The following is a description of a gene set: Human Gene Set: SMID_BREAST_CANCER_RELAPSE_IN_BONE_UP from publication Smid M, Wang Y, Zhang Y, Sieuwerts AM, Yu J, Klijn JG, Foekens JA, Martens JW (PMID 18451135) studied in species Homo sapiens We explored whether the five previously reported molecular subtypes in breast cancer show a preference for organ-specific relapse and searched for molecular pathways involved. The intrinsic gene list describing the subtypes was used to classify 344 primary breast tumors of lymph node-negative patients. Fisher exact tests were used to determine the association between a tumor subtype and a particular site of distant relapse in these patients who only received local treatment. Modulated genes and pathways were identified in the various groups using Significance Analysis of Microarrays and Global Testing. Bone relapse patients were most abundant in the luminal subtypes but were found less than expected in the basal subtype. The reverse was true for lung and brain relapse patients with the remark that absence of lung relapse was luminal A specific. Finally, a pleura relapse, although rare, was found almost exclusively in both luminal subtypes. Many differentially expressed genes were identified, of which several were in common in a subtype and the site to which the subtype preferentially relapsed. WNT signaling was up-regulated in the basal subtype and in brain-specific relapse, and down-modulated in the luminal B subtype and in bone-specific relapse. Focal adhesion was found up-regulated in the luminal A subtype but down-regulated in lung relapse. The five major molecular subtypes in breast cancer are evidently different with regard to their ability to metastasize to distant organ(s), and share biological features and pathways with their preferred distant metastatic site. Genes up-regulated in bone relapse of breast cancer., and this is the list of marker genes: TSPAN1, GATA3, CELSR1, PIERCE1, DNALI1, JMJD7-PLA2G4B, CYP2B6, MGAM, EPHA3, CRIP1, SCGB1D2, TFPI2, SLC19A2, INPP5J, TOM1L1, DUSP4, PTPRT (NCBI Gene Id 11122), TIMP4, SIL1, LRP1B, RND1, FGFR3, CYP2B7P, GSTT2, SYT1, ASCL1, KAZALD1, HBA1, REPS2, NELL2, BCAS1, SLC39A6, FBP1, GP2, IL24, TMEM101, CAPN9, TTC12, PGAP3, HMGCS2, SLC44A4, AGR2, PSD3, CEACAM5, MSMB, CITED1, SERPINA5, ACADSB, KIF5C, CLGN, MUC1, PDE4DIP, MLPH, NR2F1, PLA1A, INPP4B, CA12, ADH1B, HPX, MATN3, CHAD, MAST4, TFF3, ESR1, SEPTIN8, CEACAM6, ANXA9, TFF1, RAPGEF3, NAT1, PGGHG, SEMA3B, SCCPDH, TBC1D19, LIN7A, TOX3, SCGB2A1, GALNT7, GALNT6, PIDD1, SCGB2A2, FAIM2, PAH, ABAT, CPB1, SLC1A1, CAMP, SLC4A8, ATRNL1, PLK2, SPDEF, RETREG1, MB, GPC1-AS1, SCUBE2, GFRA1, CCNO, EVL, DCLK1